Given this list of marker genes Tent4a, Pdcd7, Baz2a, Tnks, Vat1, Pum2, Gnb3, Abhd12, Nfatc4, Fktn, Zfp169, Pea15a, Pde5a, Gm2042, Fibcd1, Chd1, Mxra7, Gas7, Marchf1, Ell2, Otud5, Rims2, Scn4b, Trim46, Hnrnpr, Kcnip1, Sox7, Vav2, Prss43, Armc9, Rtkn, Gpd1, Rnf157, Parp6, Cnot3, Wt1, Stk25, Dgkk, Nampt, Ulk3, Rgma, Hectd4, Pgs1, Klk11, Hap1, Rgs8, Dcx, Nfya, Agbl5, Vwa7, Mapkapk2, Bcl6b, Ikzf4, Stk32b, Ism2, St3gal5, Zfp512b, Ahcyl1, Ino80, Ube2h, Sema5a (NCBI Gene Id 320921), Kcnj12, Pou2f1 (NCBI Gene Id 18986), Nfix, Bmal2, Cecr2, Atxn7l3, Pitpnm3, Asb11, Sult1b1, Dr1, Ncstn, Adipor2, Zfp91, Sin3a, Setd1a, Nell2, Cux1, Lix1, Kif21b (kinesin family member 21B), Xpo7, Nectin1, Srrm4, Cdk5r2, Cpped1, Nat8l, Smarcd1, Tnrc6b, Smc1a, Usp7, here is a description of the gene set: studied in species Mus musculus from publication Chen Y, Wang X (PMID 31504780) Genes predicted to be targets of miRBase v22 microRNA mmu_miR_3087_5p in miRDB v6.0 with MirTarget v4 prediction scores > 80 (high confidence targets). Mouse Gene Set: MIR_3087_5P